Given this list of marker genes Ep300, Slc22a13, Il25, Hlx (H2.0-like homeobox), Fbxo38, Ighv5-9, Card9, Ighv12-3, C4b, Socs5, Ercc1, Ccl20, H2-Ea, Ighv8-13, Gzmm, Muc4, C9, Foxp3, Cd274, Tnfrsf1b, Dennd1b, Traf6, Iglc1, Rc3h1, Ighv6-3, Ly9, Ighv1-47, Ighv5-4, Prkcd, Mtor, Nfkbid, H2-T23, Il1b, Ighg1 (immunoglobulin heavy constant gamma 1 (G1m marker)), Ighv5-16, Clec7a, Ighv14-1, Jag1, Fcgr4, C8b, Stard7, Iglc3, Cd55b, Nlrp10, Trp53bp1, H2-Q2, Jak3, C2, Klhl22, Ager (NCBI Gene Id 11596), Atad5, C8g, Nbn, H2-T15, Ighv3-4, Lef1, Ephb2, 2410137M14Rik, Ighv1-82, Cracr2a, Ahr (aryl-hydrocarbon receptor), Raet1e, Lyst, Ifnb1, Tmem98, Ascl2 (achaete-scute family bHLH transcription factor 2), Irf4, Rab27a, Irf7, Ighv1-42, Cd81, Ighv1-63, Aire, Ighv3-6, Lta (NCBI Gene Id 16992), Ighv1-16, H2-M9, Cd80, Arid5a, Hras, Ighv1-26, P2rx7, Hc, Tnfsf13, Ptprc, Trem2, Ighv4-1, Ighv9-1, H2-M5, Enpp1, Ndfip1, BC037156, Ighv6-4, Ighv1-84, Trex1, Cd1d2, Slamf1, Ulbp1, Brd2, Mr1, Ighv1-39, Cd4 (CD4 antigen), Trpm4, Cd24a, Sash3, Ighv1-31, Azgp1, Il4ra, Ighv1-77 (immunoglobulin heavy variable 1-77), Ighv1-64, Foxj1, C8a, Cd1d1, Ighv1-80, H2-M10.6, Ighv6-7, Ighg3, Il2rb, Ighv1-12, Ighv1-24, Fcgr1, Ighv1-81, Il12b, Ppp3cb, Ufl1, Stat3, Tnfsf18, Ighv8-8, Hfe (homeostatic iron regulator), Il1rl1, Stx7 (syntaxin 7), Gzmb, Entpd7, Ighv5-12-4, Stat4, Ighv14-3, Ighv14-4, Icam1, C3ar1, Bcl6, Emp2, Nfkb2, Kmt5b, Hmgb1, Ighv11-2, Ighv8-11, Opa1 (OPA1, mitochondrial dynamin like GTPase), Serpinb9b, Il9r, Exo1, Hspa8, Ighv2-7, Ighd, Ighv8-9, H2-M10.5 (histocompatibility 2, M region locus 10.5), Gba1, Crp, Jak2, Rnf168 (ring finger protein 168), Ighv1-23, Susd4, Tfrc, Mbl2, Batf, Ighv1-72, Lilrb4b, Vsir, Ighv2-9-1, Mef2c, Fcgr2b, Pf4, Lgals1, Nckap1l, Ripk3, H2-T22, Rsad2, C1qc, Mir873a, Lig4, Nod2, Tnf, Bcl10, Ctsc (NCBI Gene Id 13032), Mbl1 (NCBI Gene Id 17194), Ighv3-3, Ighv9-2, Irf1, Lgals9, H2-T24, Phb1 (prohibitin 1), Hmces, Ighv8-4, Inpp5d, Msh2, Exosc6, Sema4a, Fcmr, Ccr2, Slc15a4, Ighv9-4, Fadd (NCBI Gene Id 14082), Fcer1g, H2-M11, Ighv9-3, Arg1, Nfkbiz, H2-T13, Ighv13-2, Ctsh, Il18bp, H2-Q10, H2-M10.1, C1s2, Ighv5-6, Kmt5c, Anxa1, H2-Q6, Csf2rb2, Zp3r, Relb, H2-D1, Ighv1-58, Kdelr1, H2-M10.3, Ccl19, Spn, Ighv1-4, Rorc, Fcgr3, Ighv1-11, H60c, Loxl3, Il23r, Ighv1-61, H2-M10.2, H2-M3, Ighv1-43, Serping1, Tnfsf13b, Rif1, Cd226, C3, Raet1d, C1qb (complement component 1, q subcomponent, beta polypeptide), Ifng, Ighe, Ighv1-34, Ighv2-9, Fosl2, Mir181b-1, H2-M1, Aplf, Fas, Ighv1-66, Cr2, Cdh17, Ighv1-55, Il1r1, Swap70, Ighv8-5, Tnfaip3, Vegfa, Slfn2, Ighv5-17, Ighv2-3, Notch1, Ada, Tbx21, Smad7, Mlh1, Ighv6-5, Gfus, Hpx, Hspd1, Ighv8-6, Parp3, Il18, Cd8a, Dpp4, C1rl, Fgl2, Nsd2, Cd27, Cd40 (NCBI Gene Id 98930), Mad2l2, H2-T3, Ripk2, C1ra, Ighv1-78, Fut7, Gata3, Msh6, Tgfb1, Il18r1, Was, Il33, C1s1, Mir326 (microRNA 326), Ighv1-53, H2-T5, Zbtb1, Ephb6, Cr1l, Treml4, Shld1, Ighv1-56, H60b, Stat6, Pms2, Il23a, Ighv7-3, Unc13d, Pvr, Serpinb9, Pdcd1, Pla2g4a, Prf1, Supt6, Xrcc4, Cd70, Ighv2-6-8, Ighv16-1, Slc11a1, Klhl6, Il13ra2, Ighv1-62-3, Myd88, Mir301, Cd69, Slamf6, Ighv10-3, H2-Q7, Myo1g, C1qa, Gapt, Fcer1a, Ighv1-76, Exosc3, Il2, Igha, Cfi, Clec4g, Stx11, Ighv2-5, Clcf1 (NCBI Gene Id 56708), Il20rb, Rora, Pou2f2, Ceacam1, Lilrb4a, Traf2, Cd74, Ighv7-1, Ighv6-6, Ighv1-75, Gimap5, Cd46, Kdm5d, Aicda, Iglc2, Fzd5, Paxip1, Ighv1-85, Hprt1 (hypoxanthine phosphoribosyltransferase 1), 6030468B19Rik, Ighv2-6, Clec4n, Il27, Tcirg1, Pagr1a, Traf3ip2, H2-Q1 (NCBI Gene Id 15006), Adam17, Shld3, Ighv1-49, Masp2, Ighg2c, Pcyt1a, C4bp (NCBI Gene Id 98275), Tyk2, Il4, Csf2rb, Dlg1, Xcl1, Il18rap, B2m (beta-2 microglobulin), Ighv1-67, Ighv2-4, Fcer2a, Ighv14-2, Prkcz, Il17ra, Il12a, Ighg2b, Tnfrsf13c, Brd4, Tap2, Il6, Il7r, Ighv5-12, Ccr7, Tnfsf4, Cd19, Otud5, Prkaa1, Gimap3, Il6ra, Ighv10-1, Nlrp3, Unc93b1, Bcl3, C1qbp, Icosl, Ptpn6, Il4i1, Ighv1-22, Crlf2, Ighv8-12, Bach2 (BTB and CNC homology, basic leucine zipper transcription factor 2), Ywhag, Shld2, Cd55, Ighv1-5, Cyrib, Ighv11-1, Igll1, Ighv1-71, Dusp22, Malt1, Cd40lg, Ighv2-2, Il27ra, Rnf8, C1rb, Zc3h12a, Ighv1-7, Klrd1, Ighv3-5, Mill1, Zp3, Pirb, Ung, Gcnt3, Ighm, Ighv3-1, Ighv1-54, Pnp, Ighv1-15, Ighv3-8, Btk, Map3k7, Il9, Rftn1, Cfh, Gadd45g, Zbtb7b, Ebag9 (estrogen receptor-binding fragment-associated gene 9), Rc3h2, Il31ra, Nectin2, Havcr2, Ighv8-2, Pkn1, Cd28, Mir181b-2, Fcrlb, H2-M2, Ighv1-50, Ccr6, Sanbr, H2-DMa, H2-K1, Il12rb1, H2-M10.4, H2-Q4, Prkcq, here is a description of the gene set: An immune response mediated by lymphocytes expressing specific receptors for antigen produced through a somatic diversification process that includes somatic recombination of germline gene segments encoding immunoglobulin superfamily domains. Recombined receptors for antigen encoded by immunoglobulin superfamily domains include T cell receptors and immunoglobulins (antibodies) produced by B cells. The first encounter with antigen elicits a primary immune response that is slow and not of great magnitude. T and B cells selected by antigen become activated and undergo clonal expansion. A fraction of antigen-reactive T and B cells become memory cells, whereas others differentiate into effector cells. The memory cells generated during the primary response enable a much faster and stronger secondary immune response upon subsequent exposures to the same antigen (immunological memory). An example of this is the adaptive immune response found in Mus musculus. studied in species Mus musculus Mouse Gene Set: GOBP_ADAPTIVE_IMMUNE_RESPONSE_BASED_ON_SOMATIC_RECOMBINATION_OF_IMMUNE_RECEPTORS_BUILT_FROM_IMMUNOGLOBULIN_SUPERFAMILY_DOMAINS